The following is a description of a gene set: species: Mus musculus The gene expression profile of the aging process was analyzed in skeletal muscle of mice. Use of high-density oligonucleotide arrays representing genes revealed that aging resulted in a differential gene expression pattern indicative of a marked stress response and lower expression of metabolic and biosynthetic genes. Most alterations were either completely or partially prevented by caloric restriction, the only intervention known to retard aging in mammals. Transcriptional patterns of calorie-restricted animals suggest that caloric restriction retards the aging process by causing a metabolic shift toward increased protein turnover and decreased macromolecular damage. Mouse Gene Set: LEE_CALORIE_RESTRICTION_MUSCLE_DN Down-regulated in the gastrocnemius muscle of aged (30-month) mice subjected to caloric restriction diet since young adulthood. from publication Lee CK, Klopp RG, Weindruch R, Prolla TA (PMID 10464095), and this is the list of marker genes: Dnaja4, Aldh3a2, Fbln2, Mapkapk2, Alox5ap, Rit1, S100a9, Dyrk1a, Relb, Ddb1, Stard3, Cplx2, Hsph1, Eif1b, Cbr2, Polb, Dmac2l, Rad50, Fbn1, Pebp1, Ddx56, Eif4ebp2, Irak1, Atoh1, Taf6 (TATA-box binding protein associated factor 6), Cish, Ss18, Ezh1, Tead3, Pfkfb1, Kpnb1, Psmd8, Galt (galactose-1-phosphate uridyl transferase), Ighm, Itgae, Cyp1b1, Ly6e (lymphocyte antigen 6 family member E), Npepps (aminopeptidase puromycin sensitive), Cyp3a13, H3f3b, Hes1, Fgf6, G3bp2, Dgcr2, Hmgn1, Nr1d1 (nuclear receptor subfamily 1, group D, member 1), Sars1, Amd1, Jak3